The following is a description of a gene set: The chemical reactions and pathways resulting in the breakdown of organic acids, any acidic compound containing carbon in covalent linkage. Human Gene Set: GOBP_ORGANIC_ACID_CATABOLIC_PROCESS studied in species Homo sapiens, and this is the list of marker genes: ADTRP, FAH, PM20D2, ACOX2, HAL, CDO1, MPST, ABHD2, DCXR, PEX2, ACAA1, KYAT1, DPEP1, ACADS, LONP2, MTLN, CPT1B (NCBI Gene Id 150414), ABCD1, MCCC1, ACOT7, NOS3, PCK2, PEX7, PAH, HADH, HADHB, GPT, SLC27A2, THNSL2, ABAT, ALDH1L2, PEX13 (peroxisomal biogenesis factor 13), HIBADH (3-hydroxyisobutyrate dehydrogenase), ARG2 (NCBI Gene Id 384), SARDH, HADHA, NAGK, GLDC, MCCC2, IDO1, GNPDA2 (glucosamine-6-phosphate deaminase 2), PIPOX, QDPR, TDO2, CBS, IVD, PCK1, HDC, ACAA2, ECH1, CYP26B1, CROT, ECHS1 (NCBI Gene Id 1892), ECI1, FMO1, ETFDH, ABCB11, SDSL, HIBCH, ALDH8A1, ACMSD, MTHFS, GLS2, AGXT2, ACAD10, TWIST1, MLYCD, ECHDC1, LDHC, SCLY, ACADVL, AASS, ALDH6A1, ARHGAP11B, PHYH, SHMT1, GLS, GLUL, ADIPOQ, SLC16A3, ACOT8, IL4I1, CPT1A, TYSND1, ALDH5A1, ARG1, HYKK, CYP4F12, LPIN1, SLC25A21, DPEP2, QPRT, BCKDHB, ACOT4 (acyl-CoA thioesterase 4), BDH2 (3-hydroxybutyrate dehydrogenase 2), PON3 (paraoxonase 3), DLST, AASDHPPT, DAO, DDAH1, ALDH4A1, AKR1D1, AUH, DECR1, PLIN5, ACBD5, ENSG00000274276, PON1, PRODH, CYP4F2, UROC1, NAALAD2, MTRR, BCAT1, ACAT1, NOS2, GSTZ1, HACL1, OTC, NUDT7, RENBP, PPARD, AKT2, ECHDC2, MIR21, DDO, AMDHD2, GPT2, NPL, LEP, ENSG00000293349, CYP26A1, PLA2G15, ABCD3, OAT, AMDHD1, CRAT, ACAD11, ACSF3, GLYATL2, ETFA, CRYL1, HOGA1, BCAT2, ATP2B4, ETFB, LPIN2, GCDH, HAAO, SLC25A17, SLC27A4, HMGCL, HPD (NCBI Gene Id 3242), LPIN3, LDHD, BCKDK, SLC25A44, KYNU, GCSH, CARNMT1, CYP4A11, ACADSB, AMT, GOT1, CYP4F3, FTCD, AGXT, TAT, MCAT, ABHD3, ACAD8, GLUD1, SCP2, BCKDHA, PCCB, SORD (NCBI Gene Id 6652), AIG1, ABCD2, GNPDA1, AKT1, ACOXL, GCAT, PCCA, CARNS1, ASRGL1, ALDH1L1, SULT2A1, DLAT, ABHD1, LDHA, PRODH2, MCEE, GLUD2, ACOX1, ILVBL, ACOX3 (acyl-CoA oxidase 3, pristanoyl), TST, IDO2, GAD2 (glutamate decarboxylase 2), DLD, CRYM, HGD, PPARA, ADHFE1, GOT2, NOS1, AMACR, IRS2, HSD17B10 (hydroxysteroid 17-beta dehydrogenase 10), HSD17B4, CPT2, CSAD, ABCD4, NUDT8, GAD1, KYAT3, ACADM, SESN2, HMGCLL1, SLC16A1, CYP2W1, XYLB, NUDT19, ETFBKMT, MFSD2A, ECI2 (enoyl-CoA delta isomerase 2), DBT, IRS1, HNMT, KMO, BLMH, CYP26C1, AADAT, EHHADH, ACACB, HAO1, PPM1K, ACADL, SDS, MAT1A, AKR1A1, AFMID, DECR2, PEX5, FAAH, RIDA